Given this list of marker genes GABRA2, BUB1, PCDHA8, STUM, PCDH1, CEP350, C6orf118, CAMKK2, SDCBP (syndecan binding protein), TRPC1, GRIA2, YWHAZ, KANSL1, UTP15, RGMB, ACAT2 (acetyl-CoA acetyltransferase 2), FGL2, PCDHA2, PIK3C2A, METAP2, FOS, ADRB2 (NCBI Gene Id 154), NRXN1, PCDHA6 (NCBI Gene Id 56142), COPS4, ZNF124, UVRAG, SOX2, HTR3E, NCAPH, WDR26, CBLL1, CADM2, SEC62, KIF5C, DOP1B, PLCB1, GAPVD1, WDR82, BAHD1, PCDHA5, KCNMA1, FBXO8, KHDRBS2, RASAL2, NREP, KLC4, NDUFS4, PCDHA13, NDST3, VPS35, PCDHA4, PCDHA10, SLBP, ANGEL1, KRTAP4-12, ZDBF2, KCTD18, ANKRD34C (NCBI Gene Id 390616), STXBP5, ZFP36L2, FAM227B, UBE2A, ZFYVE28, CDH2, ACKR4, CADPS, NMI, ANKRD34A, RHOJ, GABARAPL1, CFAP300, SOX11, WDFY3, CAST, PITX1, FAM228A, ZCRB1, RABGAP1L, SPACDR, PCDHAC1, ARF3, RAB11A, IPP, HOMER1, PAQR3, SLC25A16 (solute carrier family 25 member 16), CREBL2, GATA6, CYP26B1, PPP1R8, HS3ST5, HAP1, DPH6, PCDHAC2, ATOSA, KCNH8, ZEB1, CEACAM1, MAPK9, UBE2QL1, ADRA1A, CDC42SE1, MPP7, TMCC1, MAGI2, TMX3, CSF2RB, MOXD1, ELK4, MAP7, NUTF2, GPR171, TWF1, PDCD7, MTCP1, MLLT3, CREBRF, MMP25, TUBA1B, PRR18, PNRC1, IQCA1, COL15A1, MNT, SATB2, CERT1, HOXA13 (homeobox A13), PCDHA7, RYBP, GNS (NCBI Gene Id 2799), MEIS2, CTDSPL2, AFF2, CCSAP, SLTM, KLF3 (NCBI Gene Id 51274), LAMP2, TXNRD1, NRIP1, PCDHA12, SLC2A13 (solute carrier family 2 member 13), PCDHA1, LENG8, PCDHA3, ADGRF3, CHD6, USP21, MIB1, EXT2, MED29, RAI14, MYOG, COLEC11, PCDHA9, ZDHHC15, NEMP1, PTPRR, AJAP1, MIER3, TACC1, DNAJB1 (DnaJ heat shock protein family (Hsp40) member B1), NFIB, FBN1, NUFIP2, PCDHA11, here is a description of the gene set: Human Gene Set: MIR4802_3P species: Homo sapiens from publication Chen Y, Wang X (PMID 31504780) Genes predicted to be targets of miRBase v22 microRNA hsa-miR-4802-3p in miRDB v6.0 with MirTarget v4 prediction scores > 80 (high confidence targets).